Given this list of marker genes CYB561A3, SPTBN2, TBC1D10C, NADSYN1, CABP2 (NCBI Gene Id 53597), CCND1, ME3, MRPL11, ARRB1, KLC2, KRTAP5-9, KRTAP5-11, ANO1, RBM4, SHANK2, RAD9A, CLCF1, CD248, PPP6R3, NARS2, KCNE3, PTPRCAP, ZDHHC24, FADD, MRGPRD, CHRDL2, NDUFV1-DT, KRTAP5-7, GAB2, PGA3, TBX10, CARNS1, SYT7, SPCS2, DPP3, RSF1, EMSY (NCBI Gene Id 56946), LTO1, GPR152, FGF4, KCTD14, PGA4, KLHL35, THAP12, CCS, B3GNT6, USP35, TMEM126A, VPS37C, DGAT2, ACTN3, AAMDC, SYTL2, PPP1CA, PGA5, UVRAG, CPT1A, TESMIN, CLNS1A, CAPN5, KRTAP5-10, FGF3, CCDC81, GDPD4, TMEM126B, CD6, IGHMBP2, EED, CREBZF (CREB/ATF bZIP transcription factor), CORO1B, OR2AT4, AIP, MRGPRF, KRTAP5-8, GDPD5, SLCO2B1, PELI3, RBM14, TOP6BL, THRSP, RIN1, INTS4, CABP4, OMP, HIKESHI, PPFIA1, TMEM109, TPCN2, ACY3, CTTN, VWCE, BBS1 (Bardet-Biedl syndrome 1), POLD4, RPS6KB2, TKFC, PAK1, RPS3, TMEM134, ACER3, SPCS2P4, DDB1, TMEM216, DAGLA, GAL, SAXO4, SERPINH1, RAB1B, CD5, BRMS1, MRPL21, TMEM138, NDUFV1, SDHAF2, WNT11, XRRA1, PITPNM1, TENM4, CPSF7, CTSF, RCE1, AQP11, ANKRD13D (ankyrin repeat domain 13D), TMEM132A, PPME1, LRFN4, PICALM, CNIH2, SSH3, MAP6, CCDC87, NDUFC2, GSTP1, MOGAT2, PGM2L1, KCTD21, CDK2AP2, NEU3, NPAS4, TMEM151A, FGF19, LRRC32, CCDC83, RNF169, CCDC89, NUDT8, ALG8, MYEOV, DHCR7, TSKU, B4GAT1, MYO7A, YIF1A, RBM4B, POLD3, SLC15A3, ALDH3B2, P4HA3, SLC29A2, here is a description of the gene set: from publication Nikolsky Y, Sviridov E, Yao J, Dosymbekov D, Ustyansky V, Kaznacheev V, Dezso Z, Mulvey L, Macconaill LE, Winckler W, Serebryiskaya T, Nikolskaya T, Polyak K (PMID 19010930) studied in species Homo sapiens Genes within amplicon 11q12-q14 identified in a copy number alterations study of 191 breast tumor samples. Human Gene Set: NIKOLSKY_BREAST_CANCER_11Q12_Q14_AMPLICON A single cancer cell contains large numbers of genetic alterations that in combination create the malignant phenotype. However, whether amplified and mutated genes form functional and physical interaction networks that could explain the selection for cells with combined alterations is unknown. To investigate this issue, we characterized copy number alterations in 191 breast tumors using dense single nucleotide polymorphism arrays and identified genes with copy number gain organized into 30 amplicons. Amplicons were distributed unequally throughout the genome. Each amplicon had distinct enrichment pattern in pathways, networks, and molecular functions, but genes within individual amplicons did not form coherent functional units. Genes in amplicons included all major tumorigenic pathways and were highly enriched in breast cancer-causative genes. In contrast, genes with somatic mutations in breast cancer were distributed randomly over the genome, did not represent a functionally cohesive gene set, and were relatively less enriched in breast cancer marker genes. Mutated and gained genes did not show statistically significant overlap but were highly synergistic in populating key tumorigenic pathways including transforming growth factor beta, WNT, fibroblast growth factor, and PIP3 signaling. In general, mutated genes were more frequently upstream of gained genes in transcription regulation signaling than vice versa, suggesting that mutated genes are mainly regulators, whereas gained genes are mostly regulated. ESR1 was the major transcription factor regulating amplified but not mutated genes. Our results support the hypothesis that multiple genetic events, including copy number gains and somatic mutations, are necessary for establishing the malignant cell phenotype.